The following is a description of a gene set: Scotoma species: Homo sapiens A regional and pathological increase of the light detection threshold in any region of the visual field surrounded by a field of normal or relatively well-preserved vision. Human Gene Set: HP_SCOTOMA, and this is the list of marker genes: HARS1, MTRFR (NCBI Gene Id 91574), ELOVL4, MYO7A, CFH, PITPNM3, POC1B, GUCA1A, CNGB3, PRPF3, PDE6H, MT-ND4L, PROM1, CFI, GUCY2D, OPN1MW, CDHR1, CIB2, CFAP418, CRX, WHRN, ACO2, HGSNAT, MT-ND2, MTTP, PRPH2, DRAM2, CNNM4, MT-CYB, ABCA4, EFEMP1, CDH23, BTD, CACNA1A, DNM1L (dynamin 1 like), IMPG2 (interphotoreceptor matrix proteoglycan 2), RAB28, HLA-A, UNC119 (NCBI Gene Id 9094), MT-CO3, CEP78, MT-ND6, CFAP410, CYP4V2, RPGRIP1, CLRN1, PDE6C, ARSG, MT-ND4, PDZD7, TMEM126A, C1QTNF5, NDUFS2, RAX2, MT-ATP6, MT-CO1, RIMS1, PCDH15 (NCBI Gene Id 7397), FLVCR1, MT-TS2, PRRT2, CNGA3, ADAM9, TIMM8A, RP2, RPGR, TLCD3B, ATF6, RBP3, USH1C, OPA3, AIPL1, HKDC1, SAMD7, TRNT1, RTN4IP1, SEMA4A, MCAT, MFN2 (mitofusin 2), ESPN, ATP1A2, ITM2B, CACNA1F, DNAJC30, CYP1B1, RP1, MFSD8, RDH5, KCNV2, MT-ND5, MYOC, CACNA2D4, USH1G, MECR, TTLL5, FDXR, USH2A, NMNAT1, OPA1, MT-ND1, RHO, ADGRV1, RLBP1, GNAT2, SLC25A46, SCN1A, OPN1LW